The following is a description of a gene set: species: Mus musculus A ribonucleoprotein complex that contains small nuclear RNA U5, a heptameric ring of Sm proteins, as well as several proteins that are unique to the U5 snRNP, most of which remain associated with the U5 snRNA both while the U5 snRNP is free or assembled into a series of spliceosomal complexes. Mouse Gene Set: GOCC_U5_SNRNP, and this is the list of marker genes: Prpf8, Snrpn, Snrpd2, Tssc4, Snrpe, Txnl4a, Prpf18, Txnl4b, Snrpb, Snrnp200, Cd2bp2, Ddx23 (DEAD box helicase 23), Prpf6, Snrpd1, Snrpd3, Snrpg